The following is a description of a gene set: Human Gene Set: REACTOME_INTERLEUKIN_17_SIGNALING species: Homo sapiens Interleukin-17 signaling, and this is the list of marker genes: ATF1, MAP2K6, CREB1, PPP2R1B, MEF2A, ATF2, ELK1, TNIP2, RPS6KA3 (ribosomal protein S6 kinase A3), MAPK3, MAPK10, IL17RA (interleukin 17 receptor A), TAB1, DUSP6, VRK3, IL17C, MAPK7, IKBKB, IL17RB, MAPK9, DUSP7, PPP2R1A, IKBKG, MAPK11, IL17RC, MAP2K4, NOD1, PPP2R5D, IRAK1, IL25, PPP2CB, MAPKAPK3, TAB2, RPS6KA1, IL17A, MAP3K8, MAP3K7, MAPK1, BTRC, RPS27A, MAP2K1, FOS, RPS6KA5 (NCBI Gene Id 9252), UBE2N, MEF2C, IL17RE, SKP1, DUSP4, UBE2V1, UBB (NCBI Gene Id 91253), CUL1, IRAK2, MAPK8, TAB3, FBXW11, MAPKAPK2, DUSP3, UBA52 (NCBI Gene Id 7311), MAPK14, NOD2, MAP2K7 (NCBI Gene Id 5609), NFKB1, MAP2K3, UBC, CHUK, TRAF6, PPP2CA, RIPK2, RPS6KA2, JUN, IL17F